The following is a description of a gene set: part of: DNA Damage Reversal Reactive cellular catabolites can cause DNA damage by 6-O-methylation of guanine. 6-O-methylguanine can pair ambiguously with both C and T, and cause transition mutations. Active reversal of such damage can be facilitated by MGMT, a protein that has 6-O-methylguanine-DNA methyltransferase activity. Reactome Pathway: MGMT-mediated DNA damage reversal studied in species Homo sapiens, and this is the list of marker genes: MGMT